Given this list of marker genes PLG, SERPINE1, THBD, F12, USF1, F2, FAP, PLAUR, VTN, THBS1, F11, PLAT, KLKB1, APOH, HRG, PLAU, SERPINF2, here is a description of the gene set: studied in species Homo sapiens Human Gene Set: GOBP_REGULATION_OF_FIBRINOLYSIS Any process that modulates the frequency, rate or extent of fibrinolysis, an ongoing process that solubilizes fibrin, resulting in the removal of small blood clots.